Given this list of marker genes Tsc22d3, Hspa1a, Jun, Fos, Hspa1b, here is a description of the gene set: Genes negatively differentially expressed in cell type: CD4+ T cell upon treatment with cytokine: GITRL in mouse lymph nodes in vivo. from publication Cui A, Huang T, Li S, Ma A, Pérez JL, Sander C, Keskin DB, Wu CJ, Fraenkel E, Hacohen N (PMID 38057668) studied in species Mus musculus Cytokines mediate cell-cell communication in the immune system and represent important therapeutic targets. A myriad of studies have highlighted their central role in immune function, yet we lack a global view of the cellular responses of each immune cell type to each cytokine. To address this gap, the authors created the Immune Dictionary, a compendium of single-cell transcriptomic profiles of more than 17 immune cell types in response to each of 86 cytokines (>1,400 cytokine-cell type combinations) in mouse lymph nodes in vivo. A cytokine-centric view of the dictionary revealed that most cytokines induce highly cell-type-specific responses. For example, the inflammatory cytokine interleukin-1β induces distinct gene programmes in almost every cell type. A cell-type-centric view of the dictionary identified more than 66 cytokine-driven cellular polarization states across immune cell types, including previously uncharacterized states such as an interleukin-18-induced polyfunctional natural killer cell state. Mouse Gene Set: CUI_T_CELL_CD4_GITRL_RESPONSE_DN